The following is a description of a gene set: Mouse Gene Set: GOBP_REGULATION_OF_MOLECULAR_FUNCTION studied in species Mus musculus Any process that modulates the frequency, rate or extent of a molecular function, an elemental biological activity occurring at the molecular level, such as catalysis or binding., and this is the list of marker genes: Ripor2, Men1, Tfrc, Ptprt, Aph1a, Kdm8, Ptx3, Tmed2, Pura, Rgs8, Trim21, Cd40lg (CD40 ligand), Dnajb2, Xrcc4, Cebpg, Aurka, Trim13, Hspa1b, Nod1, Qars1, Pcna, Fem1b, Neurod2, Ahnak, Arid5b, Zfpm1, Tlr1, Hopx, Paxip1, Stub1, Ntrk1, Pot1a, Sik1, Gstp3, Serpinb9e, Spi1, Bin1, Aida, Grhl3, Pias2, Ube2s, Cdk5r1, Il18r1, Csf1r, Cav1, Kcne5, Eif2ak2, Serpinb8 (serine (or cysteine) peptidase inhibitor, clade B, member 8), Myc, Cemip, Bag2, Tnks, Bbs4, Rad50, Tlr9, Rb1, Plek, Grem1 (gremlin 1, DAN family BMP antagonist), Nod2, Slco3a1, Serpinb13, Il34, Neto1, C1galt1c1, Gckr, Cox11, Ifng, Taok3, Nr0b2, Slc5a1, Cd2ap, Id1, Bscl2, Pak1, Gstp1, Nfix, Nr1h4, Sumo1, Ikbke, Slc5a11, Abl1, Rgs7, Cib1, Ngf, Nsd1, Prkd1, Gata3, Prdx5, Rtraf, Cdc42, Mapk8ip1, Ndfip2, Dscam, Crtc2 (CREB regulated transcription coactivator 2), Ptk2b, Apoh, Dnaja3, Gnal, Spink6, Ccdc125, Guca1b, Map3k13, Rfc2, Fabp4, Parp1, Pin1, Paqr3, Oas1f, Rtn4r, Evi5l, Il5, Setmar, Ror1, Cd300a, Arhgap28, Chrm3, Ankrd54, Chaer1, Sh3bp1, Apc, Tert, Mbp, Cacng4, Ace2, Ndn, Ppp1r12a, Crtac1, Drd5 (dopamine receptor D5), Kcne2, Nedd4l, Epha1, Lrrc26, Raf1, Mastl, Shisa9, Rhoa, Slpi, Gzma, Abi3, Tmigd3, Rab11fip2, Cdc25b, Dgkh, Gstp-ps, F2r, Calm3, Usp17le, Angpt1, Fgfr4, Spink5, Nupr1 (NCBI Gene Id 80556), Nos1, Mapre1, Flot1, Atf2 (activating transcription factor 2), Traip, Arfgef1, Nmd3, Zfp462, Gsk3b, Trem2, Chtf8, Wnk3, Pim1, E130311K13Rik, Psenen, Stac, Rhoc, Sez6, Dgki, Rps3, Stox1, Lamtor5, Ppm1e, Dnaja1, Gpld1, Ppp2ca, Rnf220, Hmgcr, Hipk1, Gapdh, Phb2, Hpn, Mir744, Uri1, Sfrp1 (NCBI Gene Id 72362), Tsacc, Rictor, Sh3bp4, Ripor1, Ankrd42, Ncbp1, Crbn, Palm, Eif2ak3, Pex19, Abr, Pdgfa, Gadd45a, Ecm1, Srcin1, Csta1, Gsk3a, Arhgap6, Abcc1, Syap1, Serpinb6a, Ikbkb, Lats1, Ang6, Tmem225, Nedd9, Slamf8, Akt2, Mdga1, Gnb5, Prkn, Lrpap1, Pip5k1a, Tax1bp1, Ang4, Dvl3, Lats2, Traf6, D1Pas1, Oxa1l, Ang5, Tor1aip2, Cox17, Foxh1, Zfp36, Gadd45g, Akap6 (A kinase anchor protein 6), Hey2, Ralbp1, Chuk, Tgfbr1, Serpine1, Mapk8, Ube2l3, Ramp3, Gpr137b, Dusp1, Dab2ip, Hdac4, Nlrc4, Ccm2l, Esr1, Tnfsf11, Ar, Atp2b4, Slc37a4, Sod1, Stk38, Nfkbia, Akap7, Bcl3, Fer, Erc1 (NCBI Gene Id 78063), Mtdh, Ldb2, Ifi214, Trim6, Pik3r6, Sfn, Adora3, Cacna1c, Wdr41, Nlgn1, Arhgef5, Tsc2, Plpp3, Gla, Msh2, Itgb1bp1, Myl4, Dazap2, Atp5if1, Nog, Chrna5, Aplp2, Siva1, Ephb3, Ifi207, Agap2, Trex1, Abl2, Serpinb9, Btg1, Bves, Tfap4, Blvra, Glis2, Rgcc, Mavs, Trim30c, Bmp4, Arhgap24, Lmf1, Scn3b (sodium channel, voltage-gated, type III, beta), Map2k3, H2bc1, Smcr8, Rsf1, Trim30a, Vangl2, Dhx33, Mcrip1 (NCBI Gene Id 192173), Serpinb9g, Fnta (farnesyltransferase, CAAX box, alpha), Ttc36, Lox, Commd7, Prdx3, Plk1, Serpinb1a, Ldb1, Ctsh, Plin5, Robo1, Xcl1, Thap11, Lpar5, Vav1, Rgn, Tbx6, Dnajc24, Tnfsf18, Stat3, Sphk1, Map2k2, Heg1, Stradb, Golga2, Add2 (NCBI Gene Id 72970), E2f1, Pln, Fancd2, Bhlhe40, Ube2srt, Adgrg3, Lmo4, Mtor, Gpd1l, Brms1, Dlg1, Taf7, Tgfb2, Havcr2, Ntrk3, Apoc2l, Nr2f2, Kit, Atp13a2, Cxcl13, Traf3, Ephb6, Ppp2cb (NCBI Gene Id 52429), Grn, Ywhah, Ube2i, Cab39, Fshb, Sox11, Tgm2, Pla2r1, Atp7a, Ckmt1, Lrch1, Cdk5rap3, Arhgef10, Wnt5a, Rgs14, Fem1a, Axin1, Ifi208, Lrrc52, Hras, Ntrk2, B2m, Rdx (radixin), Dstyk, Ptpn6, Ap3b1, Sphk2, Serpinb1c, Serpinb1b, Aurkb, Ifi203, Arrb2, Ifi203-ps, Plxnb2, Zfp618, Setd7, Bcas3, Nfatc4, Prkar1a, Crb2, Tsc1, Nlrc3, Aim2, Plaur, Neil1, Snca, Rpl23, Tcl1, Abi2, Scarb1, Serpina5, Sptssb, Spink2, Pibf1, Cops5, Cldn13, Spry1 (NCBI Gene Id 24063), Gal, Tnfrsf11a, Clu, Ywhae, Dhrs7b, Sirt4, Spdye4a, Mepce, Prom2, Prkd2, Cdkn2a, Cd4, Pygo2, Calca, Rfc3, Cacna1f, Hmgb2, Card14, Scrib, Sash1, Zmpste24, Lyset, Hmgn3, Cdk12, Ezh2, Dock7, Serpinb6b, Eef1a2, Ptprf, Gemin2, Mad2l2, Htr2b, Bbln, Prkag2, Pkia, Ldlrap1, Neurog2, Spry4, Sfrp2, Trim25, Rack1, Phactr4, Oas3 (2'-5' oligoadenylate synthetase 3), Stfa2, Antxr1, Edn2, Tnf, Drd2, Cdkn1c, Smarcb1, Erp29, Tspyl2, Unc119, Wrn, Csf1, Spop, Oas1a, Prex1, Dbi, Ptpn1, Cst7, Trappc9, Bex2, Myh6, Adra2a, Rab3gap1, Cav3, Gadd45b, Dffa, Jak2, Il3, Ercc2, Lynx1, Ralb, Acod1, Tpm2, Scn4b, Osr1, Mstn, Capn3, Mst1r, Ccl19-ps6, Zfp932, Mitd1, Adcy7, Tle5 (NCBI Gene Id 14797), Arrdc4, Arhgap35, Cstdc6, Nox4, Fhl1, Adgrf1, Fem1al, Dusp10, Ifi209, Tmem168 (transmembrane protein 168), Mapre2, Spag8, Ralgapa2, Fzd6, Tpx2, Foxa2, Vps25, Vcp, Crebzf, Sting1, Nipsnap2 (nipsnap homolog 2), Abca2, Sfrp4, Synpo2, Cd40 (NCBI Gene Id 98930), Cdk5r2, Smad2, Apoc2, Vamp2, Fcer2a, Smpd1, Styx, Aktip, Begain, Rgs10, Sez6l2 (seizure related 6 homolog like 2), Rps6ka5, Pinx1, Ddit3, Sesn2, Notch1, Efna5, Ppp2r5b, Twist2, Mark3, Crh, Krit1, Adar, Capn1, Ripk3, Ankrd13c, Hdac5, Ssbp1, Neurod1, Zic2, Strada, Tafa4, Cacng5, Hamp, Pih1d1, Ikbkg, Oas1d, Il19, 1810037I17Rik, Fgf12, Wapl, Rnf207, Spatc1l, Hspa2, Tesc, Ppp2r3c, Ccl19-ps3, Pabpn1, Rap1gds1, Nfkb1, Ran, Parp9, Rassf2, Larp7, Stim2, Tmem74, Syde1, Itgb1, Nolc1, Prkca, Crnn, Camk2a, Firrm (FIGNL1 interacting regulator of recombination and mitosis), Eif4a2, Rcc2, Anxa3, Snapin, Eng, Ccnd2, Socs4, Pax6, Pik3cg, Pnkp, Cflar, Dbndd2, Agrn, Ptgis, Cat, Fxyd1, Vav3, Dusp7, Igf1 (NCBI Gene Id 320499), Prkcz, Fank1, Styx-ps, Spta1, Wnt3a, Trim5, Phlda2, Snx18, Azin2, Jup, Amot, Ccpg1, Csrp3, Gas6, Dock8, Tescl, Cnksr3, Rapgef3, Ahcyl1, Tbc1d2, Rgs16, Epm2aip1, Map3k12, Wdr24, Rapgef1, Mir205hg, Ins1, Vegfc, Epha5, Higd1a (HIG1 domain family, member 1A, NCBI Gene Id 80431), Bmp2 (NCBI Gene Id 98992), Fxyd3, Smo, Btrc, Cacna1d, Trim28, Ppdpf, Cln5, Arap1, Psmb8, Tmbim1, Tigar, Pbx1, Lfng, Il1b, Anxa4, Cdc20, Nes, Zfas1, Chi3l1, Stmn1, Etaa1, Itgav, Pin1rt1, Lars1, Zc4h2, Zc3h15, Rsu1, Il1rap, Trim31, Fgr, Nup62, Mapt, Sco1, Vav2, Wnt11, Ecsit, Cp, Fgf1, Cdk5, Stk39, Ddx11, Mef2c, Large1, Lims1, Pde3a, Foxj1, Twist1, Fbxo7, Hpca, Lhx2, Rhebl1, Ccnyl1, Adam15, Cacng2, Mndal, Nwd1, Fktn, Card10, Mdfi, Serpinb6d, Dph3, Rasgrf1, Fgf13, Timp3, Usp9x (NCBI Gene Id 77016), Iscu, Tut4, Ank2, Cacul1, Asph, Map3k1, Orai1, Prkg1, Map4k2, Bmi1 (NCBI Gene Id 12151), Hdac1, Arhgef7, Pum3, Ccar2, Net1, Sp7, Hnrnpu, Midn, Prkcq, Svbp, Coro1c, Arhgap11a, Usp6nl, Terf1, Mid1ip1, Xrcc1, Sod2, Atp2a2, Rgp1, Snx9, Akt1, Pou4f1, Rcn3, Dzip1, Pdgfrb, Nrg1, Cdkn1a, Pex14, Rgma, Ifrd1, Rangap1, Kdm1a, Ptprc (protein tyrosine phosphatase receptor type C), Plxnb1 (NCBI Gene Id 70220), Sh3bp5, Nr1h2, Hif1a, Fxyd2, Arrb1, Asap3, Psma3, Iqgap1, Polg2, Nfkbil1, Zgpat, Prkrip1, Pkn1, Stk11, Hfe, Adcyap1, Fgd2, Uchl1, Habp4, Enpp1, Serpinb9d, Cftr, Angptl4, Zfp622, Cacng7, Nhlrc1, Lrp8, Irak1, Epha4, Gas8, Nf2, Dnm1l, Plxnd1, Slc8a1, Dock9, Frmd7, Galr2, Slurp2, Cltrn, Ccnd3, Tcf7l2, Calm2, Ptpro, Cenpe (centromere protein E), Epha3, Adcy3, Zbtb7a, Mid2, Shb, Cacng8, Evi5, Rab3gap2, Nlgn2, Cpne1, Homer1, Myocd, Cnih3, Dusp22, Pten, Trib1, Ube2n, Bmncr, Cav2, Mtss2, Src, Rgs2, Map3k11, Adcy4, Map2k6 (NCBI Gene Id 26399), Fermt2, Hmga2, Fzd4, Syk, Adam17, Kcnj1, Stx4a, Rlim, Wfikkn1, Spred1, Arhgap44, Ctbp2, Bcr, Lrp6, Ccl11, Txn1, Wdr59, Spock1, Adrb2, Tiam1, Kctd7, Igf1r, Mapk14, Inpp5k, Sgsm2, Map2k1, Plcg2, Nf1, Trim30d, Hes1, Itch, Bax, Als2, Ccr7, Odam, Ikbip, Serpinb9c, Zbtb7c, Rps2, Itgb3, Tns3, Arrdc3, Prelid1, Sri (sorcin), Cnih2, Med25, 4930447C04Rik, Map2k4, Gnl3l, Lrrk2, Mst1, Pafah1b1, Mlst8, Ptprb, Pkib, Usp33, Card9, Egf, Oas1h, Eif2ak4 (eukaryotic translation initiation factor 2 alpha kinase 4), Asxl2, Ltf, Aldob, Traf1, Fzr1, Gpsm1, Senp2, Cactin, Atp1b3, Hamp2, Rgs1, Fzd5, Rasgrp2, Chrna7, Cd24a, Tmem132a, Sema4d, Ttbk2, Ccl19-ps4 (NCBI Gene Id 100040035), Rara, Tnfsf4, Msh6, Kif14, Homer3, Nrdc, Cep85, Calcr, Fbxo5, Plcl2, Rfc4, Pim2, S100a1, Jtb, Dtnbp1, Zic3, Oprm1, Irf4, Rbl1, Brd4, Mapk3, Srf, Ect2, Mrln (NCBI Gene Id 69563), Tdg, Cd84, Rtkn2, Bcl10, Gopc (NCBI Gene Id 94221), Rnf2, Trim8, Ndel1, Pdgfc, Deptor, Casr, B3gat3, Dap, Stim1, Avpr1b, Hmgb1, Apba3, Carm1, Fgfr2, Cthrc1, Fgf10, Spink1, Rapgef2, Lyn, Parp10, Eif4g1, Fbh1, Gfi1, Ulk4, Prdx2, Dmd, Hhex (NCBI Gene Id 15243), Adap1, Heyl, Smad7, Apoa5, Ifi206, Fetub, Cd74 (CD74 antigen (invariant polypeptide of major histocompatibility complex, class II antigen-associated)), Dnajb1 (NCBI Gene Id 81489), Oas1b, Irak2, Tbc1d30, Cacng3, Edf1, Eno1, Med13, Stfa3, Tirap (toll-interleukin 1 receptor (TIR) domain-containing adaptor protein), Mfsd8, Smad3, Stimate, Tlr6, Pax7, Csta3, Anxa2 (NCBI Gene Id 12306), Psmd10, Pias4 (protein inhibitor of activated STAT 4), Fgf14, Tbc1d7, Gprc5a, Serpinb6c, Xrcc6, Trim52, Gpr39, Epo, Cga, Rfc5, Hdac6, Dusp19, Fam3c, Rrp1b, Lrrc14, Cmklr1, Add1, Trim26, Cnrip1, Wwtr1, Il6, Timp1, Ndufa4, Esr2, Psap, Adgrv1, Eif3e, Runx1t1, Jmjd8 (NCBI Gene Id 72106), Akt1s1, Smg8, Tmed10, P2rx7, Agtr1b, Myd88, Nek2, Ntf3, Gpihbp1, Epha2, Rela, Sirt3, Smim6, Map2k7, Mmd2 (monocyte to macrophage differentiation-associated 2), Adra2c, Ripk2, Ttbk1, Lrrfip1, Pik3r5, Sirt2 (sirtuin 2), Il7, Zfp91, Fgfr3, Kdm5a, Nbn (nibrin), Neurog1, Mt3, Ubxn1, Tor1aip1 (NCBI Gene Id 208263), Gpr65, Cst3, Nus1, Psen1, Rpl11, Il10, Atp1b1, Rasgrf2, Chp1, Pparg, Emp2, Itga4, Ccl24, Chmp6, Msx2, Trim32, Stil, Pxn, Map3k4, Traf5, Jun, Crtc1, Cldn3, Cartpt, Kdm4d, Epb41, Garem1, Slc5a3, Irgm2, Scn1b, Kat6a (NCBI Gene Id 60407), Syngr3, Ednra, Irs2, Htt, Itga6, Kcne3, Eif3d, Agtr1a, Fcgr2b, Ppp3ca, Dock11, Smarca4, Map3k5, Erbin, Ripk4, Prox1, Camk2d, Ccl5, Otulin, Sez6l, Tceal7, Plxnb3, Nlgn3, Gata1, Met, Crhbp, Pycard, Lilrb4b (leukocyte immunoglobulin-like receptor, subfamily B, member 4B), Clspn, Calm1, Pla2g10, Arl2, Il18, Kcnrg (NCBI Gene Id 328424), Tbc1d15, Magi3, Fzd2, Nos3, Phpt1, Adora2b, Fkbp1a, Mad2l1, Xrcc5, Gclm, Timp2 (tissue inhibitor of metalloproteinase 2), Hmgn1, Ptch1, Stac2, Nme1, Tmbim6, Lgals9, Fgf23, Serpinb6e, Kcne1, Il24, Cldn5, Mcph1, Fbn1, Dapk1, C1qtnf9, Ksr1, Stfa2l1, Dnajc3, Ddr2, Tmem64, Rhbdf2, Dlgap2, Stfa1, Gsg1l, Shisa6, Tcaf1, Carf, Ern2, Gskip, Myod1, Serpinb9f, Myo5a, Tead1, Rap1gap, S100a10, Gprc5b, Traf4, Hdac2, Crk, Efhb, Plaa, Ripk1, Cdkn2d, H1f0, Csta2, Ppp1r17, Wnk2, Smarcd3, Prtn3, Actb, Psca, Adipoq, Pabpn1l, Ptk2, Ormdl3 (NCBI Gene Id 66612), Tbc1d20, Psma6, Scn2b, Insr (insulin receptor), Hnrnpk, Cdkn2b, Cln3, Mtpn, Rhog, Ccs, Abcb1b, Tunar, Hip1r, Oas1e, Pkhd1, Serpinb9b, Uvrag, Gtpbp4, Reln, Irak3, Actn2, Edn3, Ccn1, Ccnd1, Lef1, Efna1, Jsrp1, Prrt1, Ang, Septin7, Crtc3, Ctss, Vldlr, Ern1, Trim62, Rfng, Gab1, Apoa2, Daxx, Eppin, Bag5, Apoe, Cand1, Zc3h12a, Ybx2, Adra2b, Setd6, Chtf18, Apoc1, Nedd4, Limk1 (NCBI Gene Id 547389), Lilrb4a, Sympk, Slc8a3, Sfrp5, Mmd, Sp100, Flna, Ppp1r3f, Atp1b2, Ngef, Acp4 (NCBI Gene Id 546967), Nrbf2, Pitx2, F2, Ggnbp2, Sirt1, Ticam1, Ep300, Tafa1, Adam9, Ufl1 (NCBI Gene Id 67490), Gba1, Traf3ip3, Mfng, Hand1, Ywhab, Cacnb4, Mre11a, Cdc14b, Cd200, Snx13, Oas1c, Crebbp (CREB binding protein), Spry2, Gapdh-ps15, Tlr4, Ahsa1, C9orf72, Traf2, Blk, Fzd1, Ubqln1, Pnlip, Casq1, Wars1, Sox6, Nr4a2 (NCBI Gene Id 18227), Ddrgk1, Trim12a, Npnt, Mvp, Dnajb11, Rasgrp1, Cops8, Gpr35, Shank1, Ppia, Rab7b, Serpinb9h, Mex3b, Pde5a, Hspb1, Nqo1, Abcc9, Socs5, Vdr, Skp1, Dysf, Cttnbp2nl, Atp2a1 (ATPase, Ca++ transporting, cardiac muscle, fast twitch 1), Crkl, Oxsr1, Fcer1a, Ttc8, Dok7, Wnt9b, Maged1, Arhgap1, Nppa, Pdgfb, Prlr, Tgfbr3, Dynapl1, Npm1, Nlrp12, Hsf1, Angptl8, Terf2ip, Mapk8ip3, Cstdc4, Rwdd1, Lrp1, Hipk2, Dab2, Egln1, Hyal2, Wwp2, Scarb2, Vtn, Oas1g (NCBI Gene Id 23960), Ppargc1a (peroxisome proliferative activated receptor, gamma, coactivator 1 alpha), Map3k7, Thbs1, Abi1, Trim40, Pfn1, Ifit2 (interferon-induced protein with tetratricopeptide repeats 2), Egfr, Plscr1, Malt1, Bccip, Ric1, Slc8a2, Ndfip1, Tom1l1, Trim30b (tripartite motif-containing 30B), Hcfc2, Dscc1, Trim38, Hpf1 (histone PARylation factor 1), Nlrp3, Neurl1a, Efna3, Ccny, Sumo3, Reck, Adcy8, Rbck1, Wnt10b, Dact1, Gstm7, Tlr3, Plec, Strit1, Tssk4, Apc2, Ip6k2, F2rl1, Btaf1, Gch1, Sort1, Lime1, Dnajc10, Epb41l5, Trim14, Foxp3, Tpd52l1 (tumor protein D52-like 1), Prkch, Furin, Guca1a, Nek10, Hck, Trim15, Commd6, Eomes, Dennd1b, Gtf2f1, Pot1b, Tgfb1, Lif, Nherf1, Shisa7, Cth, Cnpy2, Cys1, Cblb, Ppara, Zfp90, Tlr2, Wee2, Coa8, Cbarp, Prmt2, Psme3ip1, Nkx3-1, Dab1, Tsg101, Angptl3, Dock10, Rap1a, Id2 (NCBI Gene Id 97802), Cracr2a, Tank, Mapk1, Dkk1, Aph1b, Hrc, Tenm1, Cstdc3, Cldn4, Ifi213, Fbxw7, Cimap3, Msx1, Cstb (cystatin B), Nr3c2, Ppm1f, Grp, Lrp12, Adcy2, Spindoc, Slc9a1, Chrna3, Apcs, Plau, Mink1, Tfip11, Rap2c, Nodal, Chn1, Cdc37, Clock, Spock3, Ccdc159, Bag4, Jph3, Trpt1, Prkcd (protein kinase C, delta), Becn1, Gsto1, Cytl1, Tcf3, Sdhaf4, Inca1, Grem2 (gremlin 2, DAN family BMP antagonist), Atpsckmt, Cycs, Epm2a, Myo9b, Mapk8ip2, Tnnt3, Bcl2, Arhgef2, Slc27a4, Hjurp, Msh3, Il4, Adarb1, Smad4 (NCBI Gene Id 28063), Rpl5, Gmnn, Apoc3, Bcl6, Zeb2, Rasip1, Rasgrp3, Wfdc6a, Cyp1b1, Ins2, Chtop, Cep43, Zfyve28, Trpc6, Fkbp1b, Diaph3, Kitl, Pdcd4, Wnt2, Fgf18, Bcar3, Dtx3l, Wfikkn2, Cdk5rap1, Cass4 (Cas scaffolding protein family member 4), Atr, Terf2, Lrrc38, Ppif, Rps7, Erbb2, Commd1, Rnf25, Klf4, Cln8, Ublcp1, Fgd1, Pate4, Arhgap42, Cyp27b1, Stac3, Errfi1, Edn1, Hexim2, Tnfaip3, Mtmr9, Nr1h3, Prkci, Stk36, Usp7, Tnfrsf4, Tnnc1, Rnf31, Igtp, Foxc1, Rapgef6, Slc1a1, Prss22, Pfn2, Ang2, Apoa4, Nosip, Dynap, Hand2, Sirt5, Pkp4, Mapre3 (microtubule-associated protein, RP/EB family, member 3), Irgm1, Gnaq, Mturn, Lrrc55, Tab2, Trib2, Pkd2, Pcbd1, Jph2, Dhx9, Wnt4, Ptk6, Smyd3, Dnajc9, Pla2g5, Traf3ip1, Ptpn22, Ptprj, Pirt, Ppargc1b, Vsir, Spon1, Ptpn3, Il20, Cdh3, Rock1, Tnni3, Ralgapa1 (Ral GTPase activating protein, alpha subunit 1), Ccl19-ps1, Serpine2, Casp3, Lilra5, Cdt1, Nrxn1, Fam220a, Ank3, Agt, Dnaaf11, Rabgap1, Cyld, Nvl, Tbc1d10b, Lrrfip2, Mtrr, Dennd1a, Pcsk9, Lepr, Fzd8, Trim27, Aph1c, Nfkbid, Nrxn2, Sln, Cacnb2, Tnnt2, Trim37, Id3, Rnf180, Dusp3, Blm, Kat2b, Ager, Ddx3x, Hgs, Tmem106b, Srgap2, Shh, Gmip (Gem-interacting protein), Tinf2, Trim12c, Bambi, Rfk, Cacnb3, Tex14 (testis expressed gene 14 intercellular bridge forming factor), Hipk3, Pdcd10, Pkig, Cripto, Gm2044, Cdon, Szt2, Rap2b, Kcnab1, Ppp1r3g, Ppp1r42, Rd3, Tmem132c (NCBI Gene Id 72838), Sgsm3, Psrc1, Slamf1, Ebf2, Ilrun (inflammation and lipid regulator with UBA-like and NBR1-like domains), Mmut, Map3k10, Ski, Zp3 (zona pellucida glycoprotein 3), Zc3hav1, Cblc, Isl1, Por, Adcy1, Ldoc1, Ctnnbip1, Apoa1 (NCBI Gene Id 11806), Bud31, Lep, Akap9, Ctnnb1, Tax1bp3, Dvl2, Dhfr, Dot1l, Lhcgr, Fmr1, Kcnq1, Selenon, Trib3, Gapdhrt2, App, Nlrc5, Fanca, Nr0b1 (NCBI Gene Id 11614), Pik3ca, Ereg, Mllt1, Camk1, Kcnj8, Ralgapb, Rwdd3, Slmap, Peli1, Taf3, Taco1, Rgs6, Park7, Thy1 (thymus cell antigen 1, theta), Cast, Xirp1, Ftmt, Ptpn2, Wnk1, Arhgef16, Macroh2a1, Gstp2, Il18rap, Tcim, Drd4, Pou4f2, Abcb1a (ATP-binding cassette, sub-family B member 1A), Psen2, Map4k4, Mrnip, Ceacam1, Arhgef15, Bdnf (brain derived neurotrophic factor), Rangrf (NCBI Gene Id 80408), Nts, Flt1, Hap1, Ubash3b, Ehd3, Casq2, Arhgef19, Banf1, Ccl19-ps5, Nprl2, Ptprh, Foxs1, Pthlh, Slc11a1, T, Akap5, Nfib, Acr, Sipa1l1, Vmp1, Vcpkmt, Ide, Atp2a3, Clec12b, Tmc8, Plcl1, Cdkn1b (NCBI Gene Id 12576), Pxk, Fxn, Hdac3, Niban2, Ncstn (nicastrin), Notch2 (notch 2), Creb3, Chp2, Camk1d, Spdya, Cstdc5, Cdkn2c, Card11, Gapdhrt, Chordc1, Usp44, Tm9sf5 (transmembrane 9 superfamily member 5), Kalrn, Foxa1, Slc4a1, Ccdc88a, Gdnf, Plcb1, Fgfr1, Mkks (NCBI Gene Id 99133), Fgf2, Mmp9, Drd1, Topors, Wnk4, Fgd4, Rbl2, Nphp3, Taf10, Ajuba, Tab1, Gng7, Ccl26, Ccl19